Given this list of marker genes TGFBR3, LIMD2, CD81, CD27, PRTN3, HOMER2, NDST1, IGFBP4, TSPAN6, FUCA2, CBL, SLC38A1, RNF144A, ITPR1 (NCBI Gene Id 619543), SIGLEC5, SQOR, SEPTIN11, TNFRSF13B, TRIB2, RASSF5, BCR, ACAP1, BRPF3, CTBP2, SPRED1, RALGPS2, ZFP2, SYDE2, LRRC56, SLC39A8, SYK, ITPRID2, KLHL22, PSMB8, GTF2IRD1, CHM, RGS18, F13A1, SOCS5, DNMT3A, CIMAP1B, MFSD6, MAOA, RCSD1, CYFIP2, CTPS2, SMO, FYN, DACH2, SLC4A7, BRCA2, ATXN1, PXYLP1, EPB41L2, SGPL1, DENND11, HOOK1, TRAF3IP2-AS1, RGS19, MEF2C, PDXP, CMTM7, GLUD1, LTBP1, BBS12, SMCO4, OOSP2, VEGFB, TOP1MT, SLC7A6, ADGRG3, TMEM237, SMYD3, NCKAP1L, RHOBTB3, ITM2A, ZSCAN18, PDE4B, SVIL, CDC14A, SAPCD2, LST1 (NCBI Gene Id 7940), LRCH1, EMB, SLC6A13, CENPW, HK2, HMGA2, NUBPL, ADAMTS20, STAP1, ARHGAP15, ZNF704, GALNT7, NR3C1, ARPC1B, IFT81, SOX4, SLC25A13, UBE2D1, NCF2, NQO2, DOCK9, IL31RA, MIF, F5, RPS6KA6, MYCN, TGM2, TJP2, MEI4, PANX1, KCTD1, GNG12, PSMB9, MARCKSL1, L3MBTL3, PHPT1, OAF, PDGFD, NUDT12, SMIM13, TSPAN3, PLP2, BEX1, GSTT2, CEP68, SETMAR, BAMBI, OXCT1, LRRC8D, CNN2, KCTD12, DCUN1D4, HLF, SEPTIN4, MAN2A2, REPIN1, ZNF496, PTPRCAP, LGALS1, GK5 (NCBI Gene Id 256356), ELL2, KLHL5 (NCBI Gene Id 54163), PTGR1, ATP8B4 (ATPase phospholipid transporting 8B4 (putative)), PTPN14, RCN1, KRT10, TUFT1, ALOX12, TDRKH, BEX4, MMD (NCBI Gene Id 23531), RMDN2, AGPAT2, LMO4, ZNF878, SELL, ACOT7, CNN3, CCND1, GCNT2, POLR3G, LYPLAL1, PITPNM2 (NCBI Gene Id 57605), FKBP11, MAGI3, CMA1, PTPN3, CELF2, ADGRA3, SELPLG, TGIF2 (NCBI Gene Id 60436), PTPRS, CDIP1, GMFG, PDE5A, TMSB10, RERE, KCTD14, NEDD4L, JCAD, IFNGR1, CCNYL1, SMIM36, GP1BB, MFSD13A, CTDSPL, TRAF3, GIMAP6, ANGPT1, ATXN10, MAP4K4, GGTA1, BCKDHB, PPP1R9A, GJB2, MOB3A (MOB kinase activator 3A), DOCK2, CRYL1, DNMT3B, TPK1, CD34, SDC1, CAVIN2, N4BP2L1, SLAIN1, TYROBP, NCK2, MACROH2A1, CPNE3, RUNX3, TPD52, NISCH, ADGRL2, HOXA9, EIF4E3, RSAD1, PLCB4, LIPA, PPBP, GGH, ITGAL, CCL15, AQP11, ENDOG, SHMT1, VIM (NCBI Gene Id 7431), CLEC1B, CTSC, SKIL, PHGDH, PDE3B, PTPRC, ARHGAP30, IQGAP2, PLXNC1, DOCK10, PRKD3, RGCC, ZNF518B, CPQ, CNTLN, EGFL7, PLPP2, LCLAT1 (lysocardiolipin acyltransferase 1), PAK1, ARRDC4, PLXNA2, PER2 (NCBI Gene Id 8864), GSTM5, PBX1, SATB1, ITGB3, SCML2 (NCBI Gene Id 10389), SH3TC2, RALB, PRSS50, BCL2L15, CCDC69, TM6SF1, PDIA5, WIPF1, IFTAP, TTC8, LRMDA, PDXK, HESX1, MPZL1, PDLIM1, PLAC8, WWC2, PTPN18, SCMH1, PNPO, ZFTA, NKG7, MYCT1, HLA-DMA, KIFAP3, THUMPD3-AS1, KCNAB2, DUSP2, GRB10, HPCAL1, CCDC122, SEPTIN6, H1-0, ZC2HC1A, KYAT3, GPR171 (NCBI Gene Id 29909), PDIA2, NLRC5, ZNF22, CAPG, FKBP5, FGFBP3, MEIS1, FKBP1A, CDC42EP3, LCP1, CCDC91, RAPGEF2, TASL, ZNF250, ENC1, CRLF3, KHDRBS3, IGF2BP3, SUSD2, SLC25A4, IFI16, PARD6G, NAB1, LATS2, TNS3, UBE2E2, FCHSD2, LHFPL2, here is a description of the gene set: Genes down-regulated in leukemic progenitor cells expressing activated fusion of ESWR1 and FLI1 compared to normal hematopoetic progenitors. from publication Torchia EC, Boyd K, Rehg JE, Qu C, Baker SJ (PMID 17875932) species: Mus musculus EWS/FLI-1 is a chimeric oncogene generated by chromosomal translocation in Ewing tumors, a family of poorly differentiated pediatric tumors arising predominantly in bone but also in soft tissue. The fusion gene combines sequences encoding a strong transactivating domain from the EWS protein with the DNA binding domain of FLI-1, an ETS transcription factor. A related fusion, TLS/ERG, has been found in myeloid leukemia. To determine EWS/FLI-1 function in vivo, we engineered mice with Cre-inducible expression of EWS/FLI-1 from the ubiquitous Rosa26 locus. When crossed with Mx1-cre mice, Cre-mediated activation of EWS/FLI-1 resulted in the rapid development of myeloid/erythroid leukemia characterized by expansion of primitive mononuclear cells causing hepatomegaly, splenomegaly, severe anemia, and death. The disease could be transplanted serially into naïve recipients. Gene expression profiles of primary and transplanted animals were highly similar, suggesting that activation of EWS/FLI-1 was the primary event leading to disease in this model. The Cre-inducible EWS/FLI-1 mouse provides a novel model system to study the contribution of this oncogene to malignant disease in vivo. Human Gene Set: TORCHIA_TARGETS_OF_EWSR1_FLI1_FUSION_DN